The following is a description of a gene set: from publication Schaefer CF, Anthony K, Krupa S, Buchoff J, Day M, Hannay T, Buetow KH (PMID 18832364) Human Gene Set: PID_AR_NONGENOMIC_PATHWAY studied in species Homo sapiens Nongenotropic Androgen signaling, and this is the list of marker genes: GNAI2, PTK2, HRAS, CREB1, PIK3R1 (phosphoinositide-3-kinase regulatory subunit 1), GNG2, PIK3CA, PLCG2, PELP1, GNAI3, GNB1, SHBG, MAP2K2, FOS, MAP2K1, GNAI1, MAPK1, PLCB2, AKT1, GNAZ (G protein subunit alpha z), PLCG1, RAC1, GNRH1, SRC, MAPK3, RAF1, PLCB1, GNAO1, PLCB3, CDC42, AR